The following is a description of a gene set: Genes predicted to be targets of miRBase v22 microRNA hsa-miR-6764-3p in miRDB v6.0 with MirTarget v4 prediction scores > 80 (high confidence targets). Human Gene Set: MIR6764_3P from publication Chen Y, Wang X (PMID 31504780) studied in species Homo sapiens, and this is the list of marker genes: PDPK1, ARID5B, STAU1, PRMT8, WDFY2, GPD2, GRM1, DES, FAM124A, SHC1, C18orf63, DYNLL1, DNAAF6, ZNF655, EZH1, BTBD7, AP5M1, ETS1, RNF185, FCHO2, ZDHHC11 (zinc finger DHHC-type containing 11), CHCHD3, EPHB3, PCNX1, ZNF268, TMEM60, MSI2, MGA, NRAS, NDN, KLHL9, TRABD2B, RALGAPA2, PALM, JAKMIP3, ZNF562, RUNDC3B, HDHD2 (haloacid dehalogenase like hydrolase domain containing 2), MLXIP, NHERF2, ZNF544, ZNF135, DDI2, RUSF1, CAMTA1, MSR1, TMTC2, GTF2A2, EPB41L1, CLCN5, ZFP1, ROR1, NRP2, HECTD3, ELMO2, ACSL1, BBX, SHISA7, C22orf46P, NR2C2, FNDC3A, FGF11, SLC66A3, SLC25A23, SNX30, SLC35F3, PPFIBP1, PRKCA, ITGA5, GRIK3, MBD5, EXT1, AQP9, MRAS, BHMT2, BAZ2B, ODR4, MRFAP1, SLC38A2, MTA3, ID1, UBE2D1, CELSR3, PRICKLE2 (NCBI Gene Id 166336), LSM11, ZNF426, AAK1 (AP2 associated kinase 1), ZBED1, TOR1AIP1, USP3, ZNF365, PDK3 (pyruvate dehydrogenase kinase 3), KCNIP2, KAT6A, RTL5, CHCHD4, GTF3C4, RNF2, PPP2R5E, PTBP1, PTK2, VXN (NCBI Gene Id 254778), WDFY1, INAFM2, KCNRG, LUZP1, DACH1, PARP2, LAIR1, G6PC2